The following is a description of a gene set: Reactome Pathway: Astrocytic Glutamate-Glutamine Uptake And Metabolism studied in species Homo sapiens In astrocytic glutamate-glutamine cycle, the excess glutamate released by the pre-synaptic neuron in the synaptic cleft is transported into the astrocyte by a family glutamate transporters called the excitatory amino acid transporters 1 and 2, EAAT1 and EAAT2. Astrocytes carrying these transporters exist in close apposition to the synapse to clear excess glutamate to prevent excessive activation of neurons and hence neuronal death. Glutamate in astrocytes is converted to glutamine by glutamine synthetase. Glutamine is then transported into the extracellular space by system N transporters. The glutamate in the extracellular space is available for neuronal uptake. part of: Neurotransmitter uptake and metabolism In glial cells, and this is the list of marker genes: GLUL, SLC1A2, SLC1A3, SLC38A1